The following is a description of a gene set: species: Homo sapiens Human Gene Set: chr11q13, and this is the list of marker genes: RPL36AP38, TBX10, OR2AT1P, RN7SL309P, FGF4, CHKA-DT, ENSG00000236935, TPCN2, DHCR7, NPM1P50, DNAJB6P5, RPS6KA4, TSKU, FGF19, RPS3, MIR4696, MRGPRD, LINC02747, POLA2, ENSG00000310059, ACTN3, RN7SL12P, FTLP6, ZNRD2-DT, NPAS4, RAB6A, GUCY2EP, LINC01488, KRTAP5-14P, LINC02757, STIP1, GPHA2, PELI3, NRXN2, KLC2, CCS, TRPT1, ATP5MGP1, FCHSD2, PPFIA1, SHANK2, GDPD4, RPS12P20, RNF169, C11orf24, RAD9A, SHANK2-AS3, TMEM134, NADSYN1, ARHGEF17, FAM86C1P, EMSY-DT, CATSPER1, SLC22A20P, FRMD8, ENPP7P8 (NCBI Gene Id 100421860), RNU6-1238P, MAJIN, ANO1, RNU2-23P, CTSW, ANO1-AS1, FAM168A (family with sequence similarity 168 member A), MIR4691, TESMIN, EVA1CP4, MEN1, MRPL21, RNU6-45P, ARL2-SNX15, LRRC51, TCIRG1, LRP5, C11orf68, LINC02701, B4GAT1, ENSG00000309978, UCP2, MIR3664 (microRNA 3664), MAP6, KRTAP5-8, MIR4692, MAP3K11, NUMA1, IMMP1LP1, MRGPRF, CST6 (NCBI Gene Id 1474), FOLR2, UNC93B5, GPR137, ENEMAL, SLC29A2 (NCBI Gene Id 3177), MIR194-2, POLD3 (NCBI Gene Id 10714), RBM14, EHBP1L1, UCP3, MIR7113, DPF2, FAM86C2P, DEFB108B, ATL3, RPEP6, C2CD3, LIPT2-AS1, DNAJC4, STARD10, FGF3, ATG2A, ACER3-AS1, LINC02584, SLC22A11, PPP6R3, GRK2, KRTAP5-11, KLC2-AS1, NRXN2-AS1, ESRRA, GPR152, PC, RN7SL239P, MIR4690, KCNK4-CATSPERZ, ACER3, ALG1L8P, KCNK4, NUDT8, OR2AT2P, KRTAP5-7, LINC02761, NAA40, FAM89B, TM7SF2, CYCSP27, KRTAP5-10, KCNK7, VPS51P17, RBM4, MIR548K, LINC02736, BRD9P1 (NCBI Gene Id 106481721), ENSG00000201733, KRT8P26 (NCBI Gene Id 649654), ARAP1-AS1, BATF2, CLCF1, NDUFS8, BBS1, ENSG00000261070, TRMT112, P2RY6, DPPA4P3, EEF1A1P18, CDC42EP2, ARL2, TOP6BL (NCBI Gene Id 79703), RNU6-672P, RIN1, POLD4, SF1-DT, ANAPC15, NDUFV1, CDCA5, PDE2A-AS1, GDPD5, B4GAT1-DT, RPS6KB2-AS1, CTTN-DT, LAMTOR1, TOMM20P1, PRDX5, FERMT3, MIX23P5, GSTP1, OR2AT4, AP5B1, CATSPERZ, LINC02956 (long intergenic non-protein coding RNA 2956), DPP3-DT, PGAM1P8, ZNF705EP, SLC25A45, CFL1, H2AZP4, VPS51, MIR3164, DOC2GP, KDM2A, UNC93B6, OR7E128P, YIF1A, OR7E4P, ARHGEF17-AS1, GVQW3, FOSL1, RNU6-1306P, LRRC32 (leucine rich repeat containing 32), PPME1, PDCL2P2, KMT5B (NCBI Gene Id 54794), FLRT1 (NCBI Gene Id 23769), PPP1CA, OR7E11P, KRTAP5-13P, MIR7155, MALAT1, MIR6749, PLAAT3 (NCBI Gene Id 11145), SYT12, ENSG00000251143, FKBP2, RNU7-105P, RASGRP2, OMP, CPT1A, DGAT2, C11orf86, ARAP1-AS2 (NCBI Gene Id 100506020), B3GNT6, MIR6754, PCNX3, RBM14-RBM4, RNU1-84P, OVOL1, ZDHHC20P3, UNC93B1, TSKU-AS1, GLTC1, CTTN, CABP4, ENSG00000286369, RNU4-39P, KCNE3, FIBP, TIGD3, EFEMP2, XRRA1, CNIH2, SCYL1, TOMT (transmembrane O-methyltransferase), COX8A, KLHL35, RPL31P46, CAPN1-AS1, XNDC1N-ZNF705EP-ALG1L9P, RPS3AP41, SNX15 (sorting nexin 15), MIR612, CHKA, RBM4B, RPS3AP40, RNF121, CCDC85B, P4HA3, OR7E1P, PPP1R14B, WNT11, RANP3, MAP4K2, RNA5SP343, TBC1D10C, RNA5SP342, LTO1, TPBGL, RPS6KB2, SPTBN2, SLCO2B1, SNORD15A, LRFN4, LINC02952, P4HA3-AS1, DRAP1, SF3B2, FAU, ANKRD13D, NEAT1, PHOX2A, MIR4489, SF1, COA4, PDE2A-AS2, PAAF1, BAD, PGM2L1, LTBP3, BRMS1, MIR6860, RNU7-23P, OR7E87P, SPDYC, HIGD1AP10, EHD1, ZNRD2, ZFTA, VEGFB, SMIM38, IFITM9P, GAL3ST3, MIR139, RNU6-1175P, MYO7A (NCBI Gene Id 4647), FOLR1P1, VPS51P11, OR7E126P, EMSY, KLC2-AS2, PLCB3, ZNHIT2, NDUFA3P2, ART2BP, CDK2AP2, P2RY2, MIR1237, NEU3, PPP1R14B-AS1, NUDT22, CDC42BPG, XNDC1N, RPL37P2, CTSF (cathepsin F), ACTE1P, SNRPGP19 (small nuclear ribonucleoprotein polypeptide G pseudogene 19), C1QBPP2, DNAJB13, PACS1, NAALADL1, ENPP7P7, SPCS2, TPBGL-AS1, LIPT2, ARPC3P4, UVRAG-DT, CAPN5, SLC22A12, CHRDL2, MRPL11, TALAM1, RN7SL786P, MIR6752, PLEKHB1, MIR548AL, EIF1AD, RCOR2, HMGN2P38, THAP12, DPP3, TSGA10IP, SSH3, GAL, CCDC88B, CABP2, PYGM, ALDH3B1, MIR6753, DEFB130C, OTUB1, RNU6-72P, ENSG00000255320, RCE1, MIR3165, CAPN1, KRTAP5-9, MACROD1, FAUP4, ART2P, ENSG00000255326, CCDC87, LINC02753, CORO1B, SNORD15B, ENSG00000206913, OR7E145P, ENSG00000287917, PPP2R5B, SART1, RTN3, TMEM262, MIR192, MARK2, PDE2A, SIPA1, SNRPCP14 (small nuclear ribonucleoprotein polypeptide C pseudogene 14), RNU6-216P, OR8R1P, ENSG00000300258, ZFPL1, ENSG00000286264, ATG16L2, LINC02723, LINC02953, PPP1R1AP1, RAB1B, RNU6-46P, MRPL49, MYEOV, MIR6750, NDUFV1-DT, RNASEH2C, RELT, PITPNM1, IL18BP, OVOL1-AS1, PTPRCAP, RNA5SP344, LINC01537, MUS81, HNRNPA1P40, MIR3163, INPPL1, DGAT2-DT, MIR194-2HG, MIR326, SYVN1, DEFB131B, BANF1, ALG1L9P, ARAP1, MOGAT2 (NCBI Gene Id 80168), SERPINH1, RELA-DT (RELA divergent transcript), SNX32, LINC02724, IGHMBP2, IUR1, RHOD, LINC02754, RN7SL596P, RELA, AIP, FADD, CD248, RPL15P16 (NCBI Gene Id 101060486), CCND1, KAT5, LRTOMT, MRGPRF-AS1, ARRB1, FOLR1, ACY3, MRPL48, RN7SKP243, RN7SKP297, CLPB, UVRAG, SPINDOC, FOLR3, SHANK2-AS1, ZDHHC24, TMEM151A, ENSG00000306716, CARNS1, SAC3D1, ENSG00000215841, ALDH3B2, MIR6751, MIR6879, DHCR7-DT, RN7SKP239